The following is a description of a gene set: part of: Signaling by NTRKs electronically inferred by orthology from the curated human pathway species: Mus musculus This event has been computationally inferred from an event that has been demonstrated in another species.<p>The inference is based on the homology mapping from PANTHER. Briefly, reactions for which all involved PhysicalEntities (in input, output and catalyst) have a mapped orthologue/paralogue (for complexes at least 75% of components must have a mapping) are inferred to the other species. Reactome Pathway: Signaling by NTRK1 (TRKA), and this is the list of marker genes: Mapk3, Ap2s1, Ppp2r1b, Irs1, Mapk7 (mitogen-activated protein kinase 7), Shc3, Kidins220, Mapk11, Hras, Map2k1, Ppp2r5d, Ap2m1, Ap2a1, Shc2, Ap2b1, Pik3r2, Vrk3, Ngf, Pik3cb, Shc1, Mapk14, Egr2, Rps6ka5, Map2k2, Grb2, Crk, Ralgds, Sgk1, Dusp7, Irs2, Dusp6, Frs2